The following is a description of a gene set: Systems vaccinology has emerged as an interdisciplinary field that combines systems wide measurements and network and predictive modeling applied to vaccinology. Here we used the systems vaccinology approach to study the molecular mechanisms underlying th studied in species Homo sapiens Genes down-regulated in comparison of peripheral blood mononuclear cells (PBMC) from TIV influenza vaccinee pre-vaccination versus those at day 3 post-vaccination. Human Gene Set: GSE29617_CTRL_VS_DAY3_TIV_FLU_VACCINE_PBMC_2008_DN from publication Nakaya HI, Wrammert J, Lee EK, Racioppi L, Marie-Kunze S, Haining WN, Means AR, Kasturi SP, Khan N, Li GM, McCausland M, Kanchan V, Kokko KE, Li S, Elbein R, Mehta AK, Aderem A, Subbarao K, Ahmed R, Pulendran B (PMID 21743478), and this is the list of marker genes: NPTN, VAMP8, NDUFA8, RAP2A, LMAN2L, FFAR2, ACO2, ATF1, MRPL15, GJB4, NDUFB6, TUBB, THOC2, TMBIM6, BCAP31, LYPLA1, TNFAIP8L2, CDH10, FOLR3, RNF5, ING4, LAIR1, RTCB, SUCLG1, MAP3K7, COQ2 (NCBI Gene Id 27235), RPA4, ATP5PF (NCBI Gene Id 63498), TAGLN3, PITPNB, FLJ40288, PLPBP, IER3IP1, HAX1, KLHL31, ZNF25, MTF2, CTBP2, HSPA8, THYN1, HIKESHI, HDAC2, ITPKC (NCBI Gene Id 80271), AGPS, RPS27L, PRDX1, PSME3IP1, RNF20, MTCH2, INIP, MTIF2, VPS35, ACAA2, EXOC5, TMX2, NSL1, ATP1B2, ORMDL2, TM2D1, RWDD2B, SHQ1, TADA3, ROBO2, PSMB3, MGAT2, UQCR10, SERPINB6, MAPK14, ARMC1 (NCBI Gene Id 55156), TRIM36, ATL3, PSMA7, ARV1, ATP6V0E1, KMT5B, NDUFB3, APOA4, GNPDA1, MRPS14, GTF3C6, PPP3CB, GDI2, TBCA, PSMD4 (NCBI Gene Id 5710), CSF1R, TSNAX, ABCD3, ZNF146, CD52, ZNF816, TMEM107, LRRC74A, ETFA, NUDT22, LRIF1, DGUOK, TRPS1 (NCBI Gene Id 7227), OMA1, PSMD14, HTATSF1P2, MEA1, NEDD8, TRAPPC1, USB1, ECHDC1, ICMT, CCT5, POU5F1B, GGCT, CSRP1, HCST, EFTUD2, PPA2, DNAJC7, FUNDC1, AURKAIP1, PRDX4, DYNLL1, VBP1, SERPING1, NDUFB5, ASXL2, KCTD3, ARL6IP5, COA3, PSMB2, SOX15, MRPL36, EIF4G3, SHC4, CCDC90B, DRG1, AK2, TIMM8B, NAA20, NAA38, AFTPH, GON7, CFL1 (cofilin 1), FH, ALG8, PCNA, NDUFAB1, FNIP2, POLR2G, TMEM260 (NCBI Gene Id 54916), EIF2S1, ARF6, TXNDC12, ABRACL, APOBEC3G, NDUFB4, TINF2, REEP5, ARRB1, TIMM17B, NEK7, TPST2, SCOC, ENO1, MDH1, MRPL18, LINC01144, NUTM2B, C1orf162, PSMA4, CLTC, ACADM, SELENOH, KCNE3, GLT8D1, PDHB, SUPT4H1, CYB561D2, SMIM30, PLRG1, RCAN1, WDR41, WSB2, MRPL51, TMCO1, MPDU1, DEPTOR, SIK2, PDZD11, PLAC9, NDUFB10, HDHD2, SAMD9, COMMD8, PROK1, CTNND1, JAGN1, CXCL10, CREBL2, ARPC2, MYCBP, HAUS1, ARPC4